Given this list of marker genes ADAMTS19, ACVR1, RBM15, BMP4, BMPR2, VANGL2, ID2, HEYL, PITX2, TGFBR1, RBPJ, HES1, CITED2, PROX1, ROBO1, SLIT2, SLIT3, SMAD7, EGLN1, WNT11, TBX3, ZFPM2, ZFPM1, MIR17HG, FGFR2, GJA5, SOX11 (SRY-box transcription factor 11), NKX2-5, FZD1, NSD2, SMAD4, HEY2, NOG, SOX4, HEY1, BMPR1A, MIR1-1, TGFBR2, ROBO2, NOTCH1, FZD2, TGFBR3, APLNR, TGFB2, NOS3, SAV1, FGFRL1, here is a description of the gene set: The developmental process in which a ventricular septum is generated and organized. A ventricular septum is an anatomical structure that separates the lower chambers (ventricles) of the heart from one another. studied in species Homo sapiens Human Gene Set: GOBP_VENTRICULAR_SEPTUM_MORPHOGENESIS